The following is a description of a gene set: species: Homo sapiens Human Gene Set: GOBP_NEGATIVE_REGULATION_OF_CELL_CYCLE_PROCESS Any process that decreases the rate, frequency or extent of a cellular process that is involved in the progression of biochemical and morphological phases and events that occur in a cell during successive cell replication or nuclear replication events., and this is the list of marker genes: PTEN, GEN1, TMEM67, KAT2B, CDK5RAP2, ANAPC15, E2F1, DMRT1 (NCBI Gene Id 82031), PROX1, CCND1, TELO2, RB1, APBB2, NANOS2, LCMT1, DNA2, SPDL1, MRE11, CCNB1 (cyclin B1, NCBI Gene Id 891), XPC, DCUN1D3, FBXO7, MIR15A, GPNMB, FHL1, IER3, FOXO4, CDK2, BCL6, MIR29C, JADE1, MAD1L1, DYNC1LI1, PRP4K, CEP63, USP44, BRCA1, WEE1, MIR29B1, EME2, MIR892B, MTBP, KANK2, VPS4A, MIR451A, CDK5RAP3, TOM1L2, MIR10A, CDKN1A, NEK11, AVEN, ZFYVE19, MIR133B, PRPF19, ZNF655, SKA3, PLK1, INHBA, RAD9B, RAD21, RAD9A, HINFP, MIR137, IK, KAT2A, ZFP36L1, MACROH2A1, MIR26A1, DLG1, RPS27L, CUL4A, WDR76, USP28, SDE2, TERF2, ZWILCH, BRCC3, CDT1, CDC20, MIR30C2, TTI1, CDKN2D, POC5, TIPRL, FEM1B, CAMSAP3, UFL1, KLHL22, GPR132, CHFR (NCBI Gene Id 56732), PTPN11, TP53BP1, MUS81, RPA4, SOX2, NBN, CHEK1, INTS7, SPC24, MAPK14, CDC45, ESPL1, MIR19B1, EME1, ATF2, CDC73, TTK, RAD51, RNASEH2B, FBXO6, MAD2L2 (mitotic arrest deficient 2 like 2), PRAP1, HEXIM2, DUX4, FZR1, TRIM39, BRSK1, PPP2R5B, ORC1, MIR638 (microRNA 638), TNKS, KNTC1, NDC80, ETAA1, TPR, ZC3H12D, STK38, RFPL1, AURKB, CENATAC, ATM, RPA2, RBL1, RAD1, ACVR1, TERF1, GTPBP4, CLSPN, EIF2AK4, INCENP, DTX3L, PSMG2 (NCBI Gene Id 56984), PLK3 (NCBI Gene Id 1263), MIR195, CTDSP2, WAC, RINT1, CRY1, MBTPS2, MAP3K20, MRNIP, HASPIN, CDK2AP2, TRIAP1, DOT1L, BIRC5, E2F8, BRCA2, NUBP1 (NUBP iron-sulfur cluster assembly factor 1, cytosolic), FBXO31, GPER1, BRIP1, MAD2L1, ATRIP, TAOK2, SPC25, ZNF830, LYN, FANCD2, BABAM2, BUB1B, MIR133A1, ZW10, MAD2L1BP, MDC1, PRMT2, PPP1R10 (protein phosphatase 1 regulatory subunit 10), ZNF207, RFWD3, ABRAXAS1, HUS1B, SIRT1, PRKDC, RBL2, BUB3, TAOK1, RPS6KA2, DGKZ, DACT1, H2AX, FBXO5, APC, MIIP, TOPBP1, CTDSP1, RGCC, CRLF3, BMP7, AURKAIP1, BABAM1, CDK1, OVOL1, FBXO4, MIR29A, MIR193A, TIPIN, FOXN3, ATF5 (activating transcription factor 5), BRD7, NEK2, BRD4, CHMP2A, TMSB4X, FAM107A, BMP4, TICRR, FBXO43, MDM1, NSUN2, STK33, ZFP36L2, PARP9, NME6, SMARCA5, MBTPS1, PINX1, ZNHIT1, NUF2, CACNB4, MUC1, SETMAR, SYF2, NPM1, MIR15B, PDIK1L, DUSP1, GNB1L, HUS1 (NCBI Gene Id 3364), ATR, DAB2IP, ATRX, CTDSPL, CHEK2, WAPL, BLM, ZWINT, CLOCK, CDC6, BTN2A2, HORMAD1, MSH2, HLA-G, XRCC3, NOP53, UIMC1, RBBP8, STK35, RAD17, CDC14B, LIF, PABIR1, MIR503, CCAR2, TOM1L1, CHMP4C, KLF4, TAOK3, EZH2, INIP, NABP1, GPR15LG, TPRA1, DONSON, INTS3, BUB1, SLFN11, TRIM37, E2F7, GIGYF2, CDCA8, MIR16-1, CDKN2B, NABP2, BAZ1B, NAE1, TTI2, MIR873, SKA1, KNL1, TRIP13, PKD2, TIMELESS, SUSD2, BARD1, TFDP3, TP53, PKMYT1, APBB1, RAD50, GFI1B (growth factor independent 1B transcriptional repressor), MIR424, MOS, CCNF, TREX1, KIF25, CCL2, CDC5L, CENPF (NCBI Gene Id 51468), DTL, MYO16, RBM14, RHNO1, TEX14, NAA10, ERCC6, MIR362, BCL2